Given this list of marker genes DAPK2, DAPK1, DCC, UNC5A, CASP3, MAGED1, CASP9, APPL1, DAPK3, UNC5B, here is a description of the gene set: Reactome Pathway: Caspase activation via Dependence Receptors in the absence of ligand part of: Caspase activation via extrinsic apoptotic signalling pathway species: Homo sapiens In the presence of Netrin1, DCC and UNC5 generate attractive and repulsive signals to growing axons. In the absence of Netrin-1, DCC induces cell death signaling initiated via caspase cleavage of DCC and the interaction of caspase-9. Recent reports have shown that UNC5 receptors similarly induce apoptosis in the absence of Netrin-1. These reactions proceed without a requirement for cytochrome c release from mitochondria or interaction with apoptotic protease activating factor 1 (APAF1). DCC thus regulates an apoptosome-independent pathway for caspase activation. DCC and UNC-5 are hence defined as dependence receptors. Dependence receptors exhibit dual functions depending on the availability of ligand. They create cellular states of dependence on their respective ligands by either inducing apoptosis when unoccupied by the ligand, or inhibiting apoptosis in the presence of the ligand.